The following is a description of a gene set: species: Homo sapiens Macroorchidism The presence of abnormally large testes. Human Gene Set: HP_MACROORCHIDISM, and this is the list of marker genes: AGA, PDE11A, UPF3B, MECP2, ZDHHC9 (NCBI Gene Id 93950), MED12, LHCGR, CLIC2, NF1, PRKAR1A, AKT1, H4C5, TSHB, IL1RAPL1, FMR1, RBMX, GNAS, CYP19A1 (cytochrome P450 family 19 subfamily A member 1), ARX, CHD8